The following is a description of a gene set: Enables the transmembrane transfer of an ion by a channel that opens when ATP has been bound by the channel complex or one of its constituent parts. Human Gene Set: GOMF_ATP_GATED_ION_CHANNEL_ACTIVITY studied in species Homo sapiens, and this is the list of marker genes: P2RX2, P2RX4, P2RX3, P2RX1, P2RX7, CFTR, P2RX5, CCDC51, P2RX6